Given this list of marker genes Krtap6-1, Klk8, Krtap10-27, Krt79, Lipn, Krtap9-22, Krtap3-2, Krt26, Krtap13-21, Krtap4-7, Krtap4-23, Krtap10-29, Dsc2, Krtap1-4, Krtap10-33, Krtap13-20, Cela2a, Krt24, Krt39, Krtap4-13, Krtap1-5, Krt83, Krtap5-2, Krt19, Krt4, Krt33b, Krtap13-22, Krtap9-1, Krt80, Krt71, Dsg3, Krtap19-2, Krtap5-26, Krtap5-1, Krtap19-4, Krt84, Cdsn, Krt81, Krtap2-4 (keratin associated protein 2-4), Krtap4-6, Krtap12-21, Dsg4, Krtap5-25, Krtap4-16, Krt28, Krtap12-22, Krt23, Krtap20-21, Krtap9-21, Krtap10-23, Klk14, Ppl, Jup, Krtap4-8, Krtap4-20, Klk5, Krtap5-5, Krtap5-4, Krtap12-23 (NCBI Gene Id 16697), Rptn, Krt16, Krt73, Krt76, Krtap5-23, Krtap10-10, Krt15, Krtap10-25, Krt13, Krtap19-3 (keratin associated protein 19-3), Krt82, Krt31, Krtap9-20, Krtap4-26, Krt40, Krt86, Krt17, Kazn, Krt36, Krtap16-3, Krt20, Krtap9-3 (keratin associated protein 9-3), Krtap13-1, Krt32, Krtap6-7, Krt87, Tchh, Krt33a, Lipk, Stfa2, Krtap2-20, Krtap31-2, Krtap4-22 (keratin associated protein 4-22), Krtap10-34, Klk12, Krtap8-1, Krtap4-2, Krt18, Krtap9-5, Krt14 (keratin 14), Casp14, Krtap19-5, Krtap4-21, Krtap1-3, Sprr3, Krtap10-28, Krtap29-1 (NCBI Gene Id 100462664), Krtap4-9, Krt77, Krt25, Krt35, Krt8, Krtap12-20, Dsg1a, Stfa2l1, Gm5414, Krtap6-6, Krtap31-1, Krtap10-4, Spink6, Krtap3-1, Evpl, Krtap10-30, Krtap2-22, Krt27, Krtap31-3 (keratin associated protein 31-3), Spink5, Krtap3-3, Krtap6-5, Lipm, Krtap13, here is a description of the gene set: studied in species Mus musculus electronically inferred by orthology from the curated human pathway part of: Developmental Biology Reactome Pathway: Keratinization This event has been computationally inferred from an event that has been demonstrated in another species.<p>The inference is based on the homology mapping from PANTHER. Briefly, reactions for which all involved PhysicalEntities (in input, output and catalyst) have a mapped orthologue/paralogue (for complexes at least 75% of components must have a mapping) are inferred to the other species.